Given this list of marker genes Rbbp7, Kansl1, H4c14, Meaf6, H2bc4, Ncoa1, H2bc11, H4c6, H4c18, Jade3, H4c8, Brpf1, Atf2, H2bc18, H2bc3, H4c17, Hat1, H2bc12, Kat6a, Phf20, H2bc21, H3c10, Ogt, H3c11, H3c13, H2bc15, H2bc8, H4c4, Wdr5, Pax3, H3c4, Kat7, H2bc1, H3c14, H4c12, H4c16, H2bc26, Kat8, H2bc13, H4c9, H4c2, H3c1, H3c8, Msl1, H2bc6, Brpf3, Hcfc1, H2bc23, Kansl3, Ing4, Msl2, Jade1, H3c2 (H3 clustered histone 2), Kat6b, H3c6, H4c1, H2bc14, H2bc22, H2bc9, Mcrs1, H2bc24, Kansl2, Msl3, H3c3, H2bc7, H4c11, Ncoa2, H3c15, H3c7 (H3 clustered histone 7), H4c3, Jade2, Brd1, Ing5, here is a description of the gene set: species: Mus musculus Mouse Gene Set: REACTOME_HATS_ACETYLATE_HISTONES HATs acetylate histones